The following is a description of a gene set: species: Homo sapiens AA and sulfur metabolism. Human Gene Set: MODULE_235, and this is the list of marker genes: CBS, ASS1, UBE2G1, CA5A, APOE (apolipoprotein E), GLUD1, GPT, ALOX15, CA8, GGT1, QPCT (NCBI Gene Id 25797), HMGCL, AKR1C3, IDS, PYGL, DDC, APOC1, SDS, TTLL12, GCLM, CHRM3, MTHFD1, LCAT (NCBI Gene Id 3931), FAH, GCLC, UBE2L6, SREBF1, GALNS, HERC2, MTTP, AKR1C2, ARSB, UBE2E1 (NCBI Gene Id 94682), GAD2, MMP15, GOT1, UBE2I, CA2, HMGCS1, GSTZ1, ATP8B1, ASNS, NDST1, OAT, PEPD, KYNU, LRP1, UGT2B7, MGLL, UBE2V2, LDLR, PTGIS, TPST1, ALAS1, QDPR, PAH, UGDH, PTS, ODC1, NEDD8, ALDH4A1, PHYH, CETP, PYGM, APOC4, AGXT, UGT2B10, ACY1, ICMT, CAD, ALDH3A2, CYP3A4, MAT1A, GOT2, PMVK, GCH1, ME2, HPD, AHCY, CA12, ANXA1